Given this list of marker genes SLC25A18, SLC2A9, CTNS, SLC16A1, SLC11A2, SLC25A3, SLC25A22, SLC45A3 (solute carrier family 45 member 3), SLC17A5, SLC15A3, SLC16A3, SLC45A2 (NCBI Gene Id 51151), SLC2A13, SLC45A1, SLC32A1, SLC46A1, SLC15A4, SLC2A10, SLC45A4, SLC36A3, SLC15A1, SLC15A2, SLC36A2, SLC36A1, here is a description of the gene set: species: Homo sapiens Human Gene Set: GOMF_SOLUTE_PROTON_SYMPORTER_ACTIVITY Enables the transfer of a solute or solutes from one side of a membrane to the other according to the reaction: solute(out) + H+(out) = solute(in) + H+(in).